Given this list of marker genes ACSM6, HADH, ACSM3, ECHS1, ACADS, here is a description of the gene set: species: Homo sapiens Beta oxidation of butanoyl-CoA to acetyl-CoA Human Gene Set: REACTOME_BETA_OXIDATION_OF_BUTANOYL_COA_TO_ACETYL_COA